The following is a description of a gene set: Malaise species: Homo sapiens Human Gene Set: HP_MALAISE A feeling of general discomfort, weakness, or lack of health., and this is the list of marker genes: DIS3L2, TNIP1, CR2, UBE2L3, JAZF1, SPP1, TRIM28, POU6F2, PTPN22, C4B, IL12B, C4A, KIAA0319L, IGHG1, DNASE1, FCGR3B, HLA-B, TRIP13, TLR7 (toll like receptor 7), BANK1, HLA-DRB1, BLK, TNFSF4, REST, IRAK1, PXK, IRF5, ITGAM, FCGR2B, IL10, P4HA2, PDCD1, H19, CTLA4, GPC3, ATP7B, TNFAIP3, TREX1, MECP2, MLX, ETS1, ELANE, WT1, STAT4, BRCA2